Given this list of marker genes Chmp7, Wnk1, Washc5, Vps4b, Chmp1b2, Anln, Son, Kif20b, Zfyve26, Septin4, Ank3, Ckap2 (cytoskeleton associated protein 2), Zfyve19, Actr3, Cep55, Septin2, Chmp4c, Washc1, Ect2, Arf1, Cfl1, Rab11a, Cul7, Ist1, Rhoc, Chmp4b, Exoc3, Myh14, Snx33, Septin7, Septin8, Nusap1, Birc5, Ankrd53, Cdca8, Orc4, Iqgap3, Dctn3, Plk1, Septin3, Actr2, Spire2, Mitd1, Exoc6b, Snx9, Kif20a (NCBI Gene Id 19348), Rock1, Exoc6, Septin14, Septin1, Spart, Septin6, Zfp365, Map9, Shcbp1l, Septin11, Rab35, Chmp2b, Stambp, Chmp2a, Daxx, Chmp5, Stx2, Exoc2, Kif23, Iqgap1, Rhoa, Septin12, Incenp, Rtkn, Cit, Rock2, Apc, Spire1, Efhc1, Myh10, Poldip2, Chmp3, Arl3, Aurkb, Chmp6, Chmp1b, Racgap1, Chmp1a, Cenpa, Alkbh4, Lzts2, Exoc5, Fmn2, Exoc8, Cntrob, Klhdc8b, Rab11fip3, Plec, Kif4, Bbs4, Septin5, Sptbn1, Snx18, Arf6, Spast, Luzp1, Jtb, Mtmr4, Stmn1, Mei1, Trim36, Usp8, Vps4a, Nup62, Exoc1, Pdcd6ip, Unc119, Septin10, Septin9, Exoc7, Exoc4, Rhob, Iqgap2, here is a description of the gene set: A cytokinesis that involves the function of a set of proteins that are part of the microfilament or microtubule cytoskeleton. species: Mus musculus Mouse Gene Set: GOBP_CYTOSKELETON_DEPENDENT_CYTOKINESIS